Given this list of marker genes RAC2, ARL6IP1 (NCBI Gene Id 56166), ADIPOR1, TRIB2, VHL, SLTM, PJA2, MOB1B, UBE2J1, WDR33, PCID2, THAP12 (THAP domain containing 12), PIK3IP1-DT, NUP58, USP7-AS1, PARL, SUZ12, TRAJ38, GCLM (glutamate-cysteine ligase modifier subunit), ERMARD, MRPS18B (mitochondrial ribosomal protein S18B), ITPR2, TRAJ39, TRAJ61, XRN1, ZNF846, MTRFR, IPP, MED23, MOB4, NUBPL (NCBI Gene Id 80224), ABCD3, TMEM39A, PDIA5, TRDD3, ZNF398, MCFD2, NRIP1, HMGB2, MIR4519, KLHL42, BBX, TIPRL, TRAJ24, RPS12, MIGA1, DND1P1, RBBP6, RPL41, STAG1, PRXL2A (peroxiredoxin like 2A), LINC01619, TRAJ59, AK3, LRCH4 (NCBI Gene Id 4034), PDS5B, JMJD1C, TBC1D19 (TBC1 domain family member 19), ARID1A, GALK2, SAMD8, SAR1B, SMARCD2, LINC01089, RAG1, GOLGA7, KDM5A, MCCC1, SNRPA1, TRAJ58, MPHOSPH9, OSCAR, TMEM41B, DDIT4, SARS1, ARID3A, TTPAL, CDR2, HIPK3 (NCBI Gene Id 10114), OAZ3, TRAJ29, ENPP3, SDE2, CSTF2T, SSBP2, TECPR2, C11orf24, ANAPC1P1, H2AC21, MKLN1-AS, MTCO3P12, UBXN11, CD38, COA5, TRBJ1-6, TRBJ2-5, CRYZ, RCE1, CWF19L1, SIPA1L1, CARNMT1-AS1, GPCPD1, EIF2B4, RFTN1, EDEM1, CBX3, RESF1, STAM, TRD-AS1, MED7, ZMYM3, ST3GAL6, MPLKIP, ABI1, MRPS27, EAPP (NCBI Gene Id 94452), UBE2D3-AS1, MCUB, PARP8, NIPSNAP2, APTX, TRAJ4, MIR1302-3, TRAJ35, MRPL9, MTCH1, MINDY2-DT, ARIH1, GVQW3, ACOT13, SECISBP2L, CCDC18-AS1, PTPN4, BBIP1, ARID2, KAT14, FHIP2A, RNU6-432P, SNHG5, RGS5, RAD23A, SERP1, TDP2, GTF2IRD1P1, TRAJ34, WBP4 (WW domain binding protein 4), EEF1AKMT2, ERLEC1, ATG12, HIPK1-AS1, FMNL1, BMI1, ABCB9, UBC, ITGA4 (integrin subunit alpha 4), ADA2, ATP5MC2, CYP4V2, TRAJ31, UBE2G1, TRAJ18, MIR762HG, ST3GAL6-AS1 (NCBI Gene Id 100874207), RASD1, ZNF490, MCMBP, CHRNA3, TRBJ1-5, PPP4C, ANO8, RNF216, ZNF827, ACTL6A, TBL1XR1, MYOSLID-AS1, STX18, ENSG00000232995, MAP2K2, MRPL40, TSC22D3, IRAG1-AS1, DNAJC11, MRPL35P3, SEC23IP, LRRC34, PIP4P2, AIMP1, GPBP1, H4C6, KHNYN, HRK (NCBI Gene Id 8739), RWDD1, REPS1, GATA3, IPO11, PICALM, H3C12, AKIRIN2, FAM21FP, ATP2B1, AGGF1, TAF6, MT-TR, LINC00667, WDR27, ACAD10, NDUFAF4P1 (NCBI Gene Id 100422544), ENSG00000267568, MSL2, STX16-NPEPL1, MAPK1IP1L, DNAJC25, MFSD8, ANKRD46, TYW3, LRRC37A5P, RPL28, MRPS24, TSC22D4 (TSC22 domain family member 4), RAF1, CD4, MRPS7, LRRC8D, MINDY2, PBLD, EZH2, SMIM12, BRD2, SMG1P1, RGS10, TOP2B, SLFN5, ADPGK, TRAJ9 (T cell receptor alpha joining 9), RAB6A, ETS1, LMAN2, SLC33A1 (solute carrier family 33 member 1), TRAJ32, ATRN, KYAT1, PDE7A, MARK3, HINFP, NDUFAF4, NUDCD3, SEPSECS-AS1, STK17B, C2CD5, DRG1, FBXO11, IFI16, ASTE1, CBX3P2, PNRC1, NPLOC4, ZBTB11, NEK11, ASB3, HEIH, BOLA1 (bolA family member 1, NCBI Gene Id 51027), BRD1, ANKRD24, JPX, DDX55, RRN3P1, TRAJ12, TRIM8-DT, EEF1A1, INTS2, G6PD, DNAJB14, HINT3, LRRC41, MIR6090, H2AC16, XYLT2, H2BC9, PLEKHA8P1 (pleckstrin homology domain containing A8 pseudogene 1), SF3A3, INKA1, ZNF791 (NCBI Gene Id 163049), CLTC, TRBJ2-6, COPS5, PSMC2, THAP2, LRP3, BMS1P4-AGAP5, PTCD2, METTL2B, SMG1P3, EPRS1, PRORSD1P, ZFC3H1, SLC35B3, PEX6, MIR5188, ST20, NUBPL-DT (NUBPL divergent transcript), ANO6, H2AZ1-DT, CD247, ZKSCAN8, STK36, ADAP2, CNIH1, GID8, CCNL1, TBC1D10C, TRIM52-AS1, AKNA, CD8A, NECAP1, CCDC77, ZNF592, STX16, PHIP, ENSG00000277301, RUVBL1, WASHC2C, TXNDC15, DNPH1, CDKN2C, ST8SIA4, ITM2C, KIF2A (NCBI Gene Id 3796), MBNL1, TRAJ41, MRPS31P5, SEC23A, CCDC88A, C6orf120, ITPRID2, TRAV40, SRSF2, ZNF131, WAKMAR2, ST20-MTHFS, MIR638, ZC3H7B, CDC5L, TSFM, CHASERR, H2BC3, BTG1-DT, BIRC2, PRIMPOL, DLST, ZNF143-AS1, ABHD10, NT5C, CD1C, CBLL1-AS1, TRAV29DV5 (NCBI Gene Id 28653), SH3TC1, RPSAP31, TRAJ17, ADD3, SHOC2, UBE2D3, DPY30, ZXDC, USP7, HIRA, LINC01301, ZNF440, OGFOD2, CYP51A1, MYD88, NDUFS7, BRAP, HERC3, RAB2A, MST1P2, NOL4L (nucleolar protein 4 like), NPHP3-ACAD11, POC1B-GALNT4, WDR59, KIAA0825, KLHL28, MXI1, TMEM202-AS1, N4BP2, MTBP (NCBI Gene Id 27085), ITPR1-DT, NONO, GABPB1 (NCBI Gene Id 82963), TRAV13-1, PROSER1, SLC4A4, BMAL1 (NCBI Gene Id 406), UBE2H-DT, IVNS1ABP, SMIM15-AS1, TWF1, COX16, BLOC1S6, DUSP12, ARL6IP4, KLHL7-DT, RHBDD1, PCBP1-AS1, SUGT1, GALT, FAM168A, VPS51, PLEKHF2, TRAJ51, MRPL38, H1-4, NUF2, MBTPS2, IKBKB-DT, KANSL1-AS1, TRBJ2-7, RNF19A, ZBED5, ERCC5, ZNF280D, PIEZO1, SNRPA1-DT, PTPRK, EEIG1, RSF1, PET117, TRAJ30, NMT2, RAC1, CNOT8, MAPKAPK3, C17orf75, IDE, PELI1, GABPB1-AS1, SLC35A3, TRIP4 (NCBI Gene Id 9325), CCNE2, PSMA1, UBR5, IZUMO4, TNPO1, RAD52, RAB40C, CBLL1, GALNT7-DT, CYREN, H2BC4, ALG3, BORCS5, JUND, FIRRM, TRAJ7, ZKSCAN3, RHOF, H2AC5P, IKBKB, NDUFA3, NDUFA10, CD1B, HNRNPH1, MZB1, TRBJ1-1, API5, PTAR1, TRAJ27, CDIPT, SARAF, CINP, SEPTIN9, DUS2, PPP3CB-AS1, ELK3, TRAJ22, MXD1, TRAV30, LINC01547, NIPBL, MAML1, GNAQ, CDC42SE1, MIR5696, SPNS1, H2BC6, PRKACB, H2BC7, NPHP3, PSPH, TATDN3, TNFAIP3, MMADHC, PIGN, ALG2, TCF12, BUD13, RPL4P1, VARS1, SOS1, SUMO2, DNTT, COA1, RSAD1, TSPAN5-DT, MARCKSL1P2, TRAJ20, TRAJ26, FAF1, MFSD11, PIK3IP1, ITK, YTHDF2, TRAJ45, C1orf220, GRAMD1B, PHF21A, SRI, MTCL2, GARS1, TRBJ2-2, TRAJ42, DCUN1D1, FBXO4, DNAJA1, PSMF1, BCL11B, TRIR, MSL1, PPP1R9B, SRD5A3, PLAGL2, PTBP3, SEMA7A (NCBI Gene Id 8482), HDGF, OTUD1, LAMTOR5-AS1 (NCBI Gene Id 101410535), GRSF1, MIR4727, CCT6B, SETD1B, ZNF410, TRAJ19, GADD45B, MKRN1, CSPP1, DNAJB11, RASSF5, SNX17, MANEA, TOB2, METAP1, DIPK2A, KMT5B, ZC3HAV1, RPTOR, TMEM41A, ZDHHC7, INTS6-AS1, CDIPTOSP, CWC27, EPHB6, SNORD118, METTL18, CLEC16A, ABHD18, MGAT4A, VWA8, ADA, MRPL1, TSPAN5, LAT, GOSR2, CNPY4 (NCBI Gene Id 245812), DGKA, MAL-AS1, ANXA2R, TUBA1A, GLS, PCBP2, HMGB1, TRAJ49, RASA1, SKP1, COPS7B, RERE, AKAP9 (NCBI Gene Id 10582), TXNDC17, TRAJ8, MIR3924, MRPS2, MCM9, ACSL3, CSNK1A1, NLRX1, CMTR1, BTG2-DT, EPM2A-DT, SMC3, KANSL2 (NCBI Gene Id 80180), CBX4, CASP3, GIT2, TRAJ54, MRPS35, MIR3665, TXNL1, HIVEP2, POLR2A, FAM187A (NCBI Gene Id 100528020), TRMT61B, MIR5091, OARD1, UBE2E3, CASP7, PSEN1, TMEM167B, ANKRD44, GCA, TUT7 (NCBI Gene Id 79670), UBQLN1-AS1, KCNIP2-AS1, H1-10, TRBJ2-1, TAF1D (NCBI Gene Id 79101), ANAPC5, TRAJ33, GTPBP3, ATP23, IRAG2, NUP50, GARS1-DT, ARK2N, MALAT1, FLI1, TRAJ52, TRBD1, SRP9 (signal recognition particle 9), HIPK1, PIK3CB, ZNF710, HNRNPU, FRA10AC1, SLAIN1, TRAJ46, AP1S2, HEBP2, DHX30, TTC32-DT, EZR, ELF1, KIAA0753, INTS8, DTWD1, SUGT1-DT, PIK3R1, LINC01465, H2BC5, SREK1IP1, ARHGAP26, ZNRF2, MYCBP2, HDAC7, GGA3, VAPA, DYNLT2, SMIM13, C21orf91, ABLIM1, KCMF1, TRIM8, RBM39, GBF1 (golgi brefeldin A resistant guanine nucleotide exchange factor 1), MRPS31, UTP3, TMEM222, CBLN3, CYB5B, TMEM68, DDX17, TRAF6, BOD1L1 (NCBI Gene Id 57219, biorientation of chromosomes in cell division 1 like 1), FIP1L1, REXO4, CXCR4, PTK2B, MPPE1, PSMD6, GLUD1P3, ATRIP, VGLL4, OGA, ENSG00000282936, ARF1, AKR1D1P1, ZNF56P, PDSS1, KRR1, CUL5 (cullin 5), POC1B, H2AC8, VPS33A (NCBI Gene Id 65082), SLFN13, HNRNPA2B1, SGPP1, SEPSECS, SNHG7, TRBJ1-2, IDH1-AS1, UBTF, SPMIP4, SPEN-AS1, TRAJ43, IL6ST, USP48, NSD3, BRWD1, H2BC11, ABHD16A, PNRC2 (NCBI Gene Id 55629), CHD2, RPL22L1, INTS6, CERT1, SLC25A3, ROCK1, SATB1-AS1, NUP50-DT, TPI1P2, TSPAN10, FLNB, MFSD10, CD3G (NCBI Gene Id 917), DEFA6, C6orf62, ATP6V1B2, GTF2E2, SQOR, KDM5B, ATR (NCBI Gene Id 57307), VWA8-AS1, MIR181A1HG, GADD45A, IKZF1, ROBO1, COX19, PIERCE1, MEF2A, CUL4A, UQCRH, TLE5, FANCG, ZNRF1, ZFP36, MT-TL1, UCP2, RBMX, IFTAP, ING2, GPR199P, CUL3, SLC16A10, MRPL13, ZBED5-AS1, HECTD1, TRBJ2-2P, CCDC117, TBL3, ARL4C, SUGCT, RNF126, SCAMP1, DNAJC25-GNG10, FOXO3, EIF4G2, TRAJ23, RNF6, C4orf33, MED17 (mediator complex subunit 17), ENSG00000246308, NDUFV3, FAM229B, CSNK1G3, SNORD50B, DNAJC27, HEATR6-DT, EXOC2, PPP1R10, METAP2, SATB1, CLK1, ZNF786, C11orf68, LRR1, KANSL1, ZFAND5, XBP1, KRAS, CD2, SUZ12P1 (NCBI Gene Id 651491), ULK4, TMEM35B, TLE4, MTND5P11, FITM2, POFUT1, TRAV18, HADHB, EFCAB7, H3C4, POMP, ARHGDIB, SRSF3, KIN, LARP1, ITGAV, RNASEH2B-AS1, H3C1, ARHGEF37, NHLRC3, ZMYM5, MT-TP, TRAJ13, MOB3A, OR10T2 (NCBI Gene Id 79510), SPG7, EIF2A, RNA5SP21, EIF2D, NSUN6, RNF144B, VPS36, SIRT6, MRPL30, PLEKHM2, TRIM52, SNAPC3, DAPK1, CDKN2AIPNL, FAM98B, TM2D3, LSM11, MTERF4, KLHL24, TGS1, MAPK14, PSMD9, ATP5F1C, ANKRD13C-DT, FHL2, GLUL, NDUFAF1, H2BC8, TRBJ2-4, LAMP1, TRAJ56, GABPB2, HEXIM2-AS1, PIP4K2A, CFAP298, DNAJB6, MT-ND1 (mitochondrially encoded NADH:ubiquinone oxidoreductase core subunit 1), MIR3188, MIRLET7I, C3orf33, NCAPG, DAP3, ITGB3BP, FBXO24, TTC7A, N4BP2L2, RANBP9, KLC2, TRAJ48, SCAMP2, KLHL7, H3C10, STAG1-DT, LRRC8A, NUDT4, PELI2, ARRDC2, RPL12P38, FAM227A, EFTUD2, CTCF-DT, TNPO3, SLC3A2, B2M, ZNF425, SNHG12 (small nucleolar RNA host gene 12), GET1, LINC03072, BDNF-AS, DDX46, EIF2B1, ABCA1, DRG2, APPBP2, MCPH1, ARL5B, ATOSA, METTL21A, TMEM30A-DT, MRPL16, DNAJC27-AS1, MIR3678, KLHL6, ZNF394, RIMKLB, DNM2, MITD1, H2AC17, UBA5, LOH12CR2, SPRY1, DNAJB1, KDELR2, H3-3A, PATL2, MTMR4, KMT2E-AS1, RNF38 (NCBI Gene Id 64796), TMSB4X, UBQLN1, CHTOP, FBXW7, SLA, TRIM25 (tripartite motif containing 25), TUBE1, TAB2, LAMTOR5, DPP4, IL17RE, BCL2L1, LRRC57, TRAV8-6, NECAP2, NFE2L2, NFATC3, MIR4734, AAMDC, MCM8-AS1, ATP2B1-AS1, RB1CC1, TAF1B, EPC1-AS2, UQCRC2, ERBIN-DT, ARMC8, HAVCR2, ZC3H4, DDHD2, IDH1, BRD4, APPBP2-DT, USP8 (NCBI Gene Id 9101), OSBPL5, NDUFC1, ADD3-AS1, TRAJ44, MRPL44, SELENOH, PSMD12, TRNAU1AP, DNMT3A, BRF2, TRIM33, CREM, LRP12 (NCBI Gene Id 80002), HECA, NXF1, RNF168, TRAJ25, GFI1, RBM25, RINT1, RABEP2, CEP70, DR1, IFT57, RPS29, RELCH, HSPA8 (heat shock protein family A (Hsp70) member 8), SMYD3, LEF1, RPL36, DIDO1, TBCK, MIR142HG, TRAJ6, CCDC103, YARS1, CD3D, KAT6B, STYX, TAMM41, STX18-AS1, PHYH, BCOR, DYRK1A, ACAD11, TRAJ28, PLEKHG1, GSK3B, BCL11A, RPS15A, VPS4A, UQCC2, MRPL24, RNF34, MKRN2, GUF1, CARMIL2, SELENOOLP, EDEM3, RPL38, H1-2, GGPS1 (geranylgeranyl diphosphate synthase 1), LRRFIP2, ARL8B, LINC00663, SPACA6, ZDHHC15, TSPYL2, CNOT4, PARP12, UBXN2A, TEFM, YY1AP1, NOP14-AS1, CASP8, CFLAR, TRAJ10, PCLAF, MFSD14A, AGFG1, SMARCE1, PUM1, CHAMP1, EIF4A2, H2AC6, PTPRA, ADAM10, PTPN2, TAF13, IL20RB, CTDP1, DNAJC2, TRAJ11, CARINH, GPLD1, G2E3, GRAP2, ABCC5, CDK13, SLC46A3, ECE2, HEXIM2, EPB41, ATP5IF1, RNF103-CHMP3, PNRC1-DT, TRAV8-3, ZNF770, BUD13-DT, MRPS35-DT (NCBI Gene Id 107984461), VTA1, ERBIN, TRAF3IP3, ADORA2A, DRAP1, CHI3L2, MDM2, ARPC3, USP30, GTF2H3, NUP54, CITED2, RORC, H2BC17, ARID1B, ZNF706, CD1E, POR, ATF1, CFAP298-TCP10L, CCNG2, TRA2B, AUNIP, IFIH1, FAM227B, HAUS2, SEC61B, BMS1P4, PDE6D, RSU1, POLM, NEIL1, TRA2A (NCBI Gene Id 29896), TRANK1, TRAT1, RNF149, TEDC1, TRAJ47, MEMO1, LAIR1, LINC01891, SSBP3, SEC23A-AS1, NEMF, MX1, PCDH9, ENSG00000233230, TRAC, KMT2E, ACTB, TBCCD1, DCAF16, CROCCP2, ZNF431, SNORA16A, ZBTB4, ZBTB26, SGK3, ITPR1, TRDJ1 (T cell receptor delta joining 1), SMAD1, TRAJ53, ARPP21, TMEM30A (transmembrane protein 30A), DIS3L2, RHOH, UBE2L6, PURA, USP3, PDHX, MKLN1, ABALON, AP3S1, DUSP2, H2AC7, HSD17B11, CRLS1, ANXA2R-OT1, VASP, SCAF8, UBE2E3-DT, CWC25, NFKBIA, TRAPPC10, MT-ND4L, CREBL2, FBXO30, GNB2, RNF141, UNC50, CD99, SPAST, NSL1, CYB561D1, IL6ST-DT, SLX9, SCAMP1-AS1, PPP1R35, CXXC5-AS1, LRRC8D-DT, TRAJ60, EPC1-AS1, STOML2 (NCBI Gene Id 30968), SERTAD2, H3-3B, ASB6, CLEC2B, ZNF207, GSK3B-DT, TMEM101, TMEM179B, S100PBP, NDUFA4, NR3C1, ZNF143, TMBIM4, EHD1, SMIM27, PTK7, RBM5, POLK, NCOA1, FLJ38576 (NCBI Gene Id 651430), CSNK2A2, STAM-DT, DDX31, THEMIS, MT-ND4, CDC42, ZBTB34, MYL12A, ARAP2, INTS15, MAD2L1BP, GUK1, TRIM11, TECR, RN7SL521P, CNOT6L, TOGARAM1, here is a description of the gene set: species: Homo sapiens Genes containing one or more binding sites for (RAG1) in their promoter regions (TSS -1000,+100 bp) as identified by GTRD version 20.06 ChIP-seq harmonization. Human Gene Set: RAG1_TARGET_GENES from publication Yevshin I, Sharipov R, Kolmykov S, Kondrakhin Y, Kolpakov F (PMID 30445619)